Given this list of marker genes WDR90, KAT2B, CEP192, NUP62, CDK2, C2CD3, VPS4B, CDK5RAP2, CEP135, C10orf90, CEP295, CEP63, CCDC78, CEP85, CEP44, CCDC61, MDM1, CETN2, KAT2A, CCDC15, CEP152, ALMS1, CDC20B, BRCA1, POC5, CEP120, TRIM37, SPICE1, CETN1, E2F4, STIL, DEUP1, CHMP2A, CCP110, PLK2, POC1B, SASS6, OFD1, KIAA0753, CEP72, MCIDAS, PLK4, WDR62, RTTN, RBM14, CNTROB, NPM1, CCDC57, CEP76, CEP295NL, CENPJ, PPP1R35, here is a description of the gene set: A cellular process that results in the assembly of one or more centrioles. Human Gene Set: GOBP_CENTRIOLE_ASSEMBLY species: Homo sapiens